The following is a description of a gene set: studied in species Homo sapiens Human Gene Set: GSE42088_UNINF_VS_LEISHMANIA_INF_DC_4H_DN Leishmania major infected human dendritic cells (DCs) exhibit a marked induction of IL-12 ultimately promoting a robust Th1-mediated response associated with parasite killing and protective immunity. In this study, we utilized Affymetrix Genechips to globally assess the host cell genes and pathways associated with L. major infection during early infection (2, 4, 8, and 24 hrs) in human myeloid-derived DCs. Bioinformatic analyses of the hybridized microarray chips identified genes, represented by 848 unique probe sets, which, when compared to uninfected samples were observed to be significantly differentially expressed by one-way ANOVA. Altogether, the data provide a genome-wide perspective on the transcriptional influences Leishmania species exert within human DCs during early infection, and provides a platform for further investigations toward functionally characterizing candidate genes of importance to the IL-12 based immune response to infections. In the current study, we further investigate the L. major infected DC transcriptional during early time points after infection via microarray analysis. Genes down-regulated in dendritic cells: untreated versus 4h after infection of Leishmania major. from publication Favila MA, Geraci NS, Zeng E, Harker B, Condon D, Cotton RN, Jayakumar A, Tripathi V, McDowell MA (PMID 24808365), and this is the list of marker genes: SCPEP1, TIPARP, ICAM2, BAP1, FAAH, RPS13, MAP4K4, RPS24, RPL39, OSBPL7, SRSF5 (NCBI Gene Id 6430), MXD3, BEGAIN, BTF3, RPS11, NLRP1, RPL31, ERP29, ELF1, STX11, CD37, BTG1, NR1H2, ZCCHC24, NACA, GBP2, STK10, RPL7, RAP2B, RPS10P5, CSF3R, HLA-DPB1, MTMR11, ILVBL (NCBI Gene Id 95885), ITPRID2, CYP21A2, RPS8, ZNF394, CHST7, SLC25A6, MAP1LC3B, HLA-DRA, AQP5 (NCBI Gene Id 8084), ELF4, ITIH3, HLA-F, ART1, DCAF1, RACK1, RPS18, TSC22D3, SCNN1D, CLK3, GAB2, MTMR3, RPS15A, S1PR4, GABARAPL1, EEF1G, ARHGEF1, EPRS1 (NCBI Gene Id 2058), RPS9, RPL38, FAU, RASGRP2, PABPC4, PRKRIP1, CAPN2, RSPH6A, MAP2K3, KRT17 (keratin 17), EIF4B, RPS7, NR4A2, CRBN, RNF2, TENT5C, RPLP2, RPL37, CHMP1B, PCBP2, TFF2, RIN3, INPP5K, CFD, KLF2, TLE5, HLA-DQB2, AKIRIN1, RSL24D1, ADD3, PTP4A1, TOE1, EIF3E, PARP16, RPL11, SP100, IFITM3, RPL27, TPSG1, PPCDC, KHDC1L, CYTIP, PMAIP1, NTRK1, SERP1, RPL21, ERBB2, RPS14, ARL4C, CCNG1, TOX4, RPL28, PRNP, HLA-J, RPL26, RPL30, RPL35A, RPL13, KCNQ1 (potassium voltage-gated channel subfamily Q member 1), OXA1L, RPL8, USP19, CPVL, KLF10, DDX3X, RPS19, CCNL1, PRDM16, USP7, OSM, HMGB2, MTMR12, RPL10, MYO1A (NCBI Gene Id 4640), SRSF3, KLHDC4, FAM53C, EIF3F, SF3A1, SNRK, NOP53, RPL18, RPL13A, MARCHF8, CD69, JUND, RPL27A, RPLP1, RPS16 (NCBI Gene Id 6217), TLR4, MTCH1, RPS4X, ROBO3, PPP1R15A, RPL22, PTGS2, SIGIRR, NOS3, TMEM8B, SMARCD3, TREM1, SNHG32, HLA-DQB1, RBM38, MXI1, PTGER4, DNAAF8, RPS29, BPI, EIF3L, FOSB (NCBI Gene Id 2354), SAP30BP, ICAM3, DUSP1, CIRBP, NR4A1 (NCBI Gene Id 93352), EIF3H, CD55, BTG2, PTK2B, PXN, UBA52, DNAJA2, MEF2C, S100P, CXCR4, APOBEC3A, RPL34, IFRD1, RARA, YPEL5 (yippee like 5), OASL, RPL32, EEF1D, PDE9A, CD244, ZXDC, CD74